The following is a description of a gene set: Pathway Definition from KEGG: PDGF -> PDGFR -> PLCG -> IP3 -> Ca2+ -> CALM == CAMK Human Gene Set: KEGG_MEDICUS_REFERENCE_PDGF_PDGFR_PLCG_CAMK_SIGNALING_PATHWAY species: Homo sapiens PDGF-PDGFR-PLCG-CAMK signaling pathway. Pathway ID: N00028. Pathway type: Reference. Pathway class: nt06273 Glioma., and this is the list of marker genes: PLCG1, CAMK4, PDGFB, CAMK1G (NCBI Gene Id 89759), CAMK2B, CAMK1, CAMK2G, PDGFRB, CALM1, CALM3 (NCBI Gene Id 808), PLCG2, PDGFA, CAMK2D, CAMK2A, PDGFRA, CAMK1D, CALM2 (calmodulin 2)